The following is a description of a gene set: A process in which a host organism modulates the frequency, rate or extent of viral genome replication. Mouse Gene Set: GOBP_MODULATION_BY_HOST_OF_VIRAL_GENOME_REPLICATION species: Mus musculus, and this is the list of marker genes: Fmr1, Stom, Fbxl2, Ccl8, Eif2ak4, Tbc1d20, Zc3h12a, Eef1a1 (NCBI Gene Id 13627), Zfyve1, Phb1, Vapa, Pik3c3, Vapb, Smc5, Ppib, Prkn, Ccnk, Smc6, Ddx56, Tmem41b, Nucks1, Ythdc2, Hspa8